Given this list of marker genes Qki, Csf1r, Tgfb1, Vps13a, Gba1 (glucosylceramidase beta 1), Tlr4, Ccdc39, Nr3c1, Naglu, App, Tlr2 (NCBI Gene Id 24088), Itgam, Ndp, Enpp1, Mfsd8, Myd88, Tspan2, Vps54, Nrros, here is a description of the gene set: The process in which a relatively unspecialized cell acquires specialized features of a microglial cell. Microglia are glial cells that act as the immune cells of the central nervous system. They form part of the supporting structure of this system. Mouse Gene Set: GOBP_MICROGLIA_DIFFERENTIATION species: Mus musculus